The following is a description of a gene set: studied in species Homo sapiens from publication La Manno G, Gyllborg D, Codeluppi S, Nishimura K, Salto C, Zeisel A, Borm LE, Stott SRW, Toledo EM, Villaescusa JC, Lönnerberg P, Ryge J, Barker RA, Arenas E, Linnarsson S (PMID 27716510) Human Gene Set: MANNO_MIDBRAIN_NEUROTYPES_HPROGFPM Cell types are named using anatomical and functional mnemonics prefixed by 'm' or'h' to indicate mouse and human respectively: OMTN, oculomotor and trochlear nucleus; Sert, serotonergic; NbM, medial neuroblast; NbDA, neuroblast dopaminergic; DA0-2, dopaminergic neurons; RN, red nucleus; Gaba1-2, GABAergic neurons; mNbL1-2, lateral neuroblasts; NbML1-5, mediolateral neuroblasts; NProg, neuronal progenitor; Prog, progenitor medial floorplate (FPM), lateral floorplate (FPL), midline (M), basal plate (BP); Rgl1-3, radial glia-like cells; Mgl, microglia; Endo, endothelial cells; Peric, pericytes; Epend, ependymal; OPC, oligodendrocyte precursor cells., and this is the list of marker genes: SDC2 (NCBI Gene Id 6383), HMGN2, SVIP, CHEK1, LMNB1, SYT4, PIMREG, HELLS, SCARNA22, RPL18, FREM1, LTBP1, RFX4, VWCE, CIP2A, MAGOHB, ALDH6A1, H3C2, CSRP2, MLLT3, FOXA2, HES1, LRATD2, ACTL6A, PLEKHA5, TYMS, ASPM, UCP2, LGR5, NPM1, RPA3, GPRC5C, PLIN3, TCF12, N4BP3, PGGHG, H2BC11, IMMP1L, PIF1, ANP32E, HJURP, PLIN2, CHST9, ARHGAP11A, PROM1, SLC6A8, TMPO, SNRPF, ZFP36L1, RPL23A, KNL1, SPAG5, IGDCC4, PTTG1, NXPH2, OTX2-AS1, HMGA1, SIVA1, CKAP2L, CCDC34, GASK1B, CDC25C, EFS, WNT1, AK4, ANLN, SPDL1, TENM4, CNPY1, MAP3K20, VIM, YAP1, CKS1B, DSG2 (NCBI Gene Id 1829), RNF175, HNRNPA1P1, FLRT2, PKIB, TOP2A, INPPL1, MAT2B, HMGB2, KLHDC8B (kelch domain containing 8B), TP53TG1, NAP1L1, H4C6, EN2, CAP2, ATAD2, CLSPN, MMP2, CHAF1A, RPL26, MBNL2, PRTG, SGO2 (NCBI Gene Id 151246), HMGN5, TWIST1, CHRDL1, KIF2A, JAM2, REST, GTSE1, RPL36A-HNRNPH2, DCC, COL2A1, KIF14, BRCA2, BMP7, DBF4, KIF11, SFRP2, PHGDH, DEK, TMSB15A, CDC25B, C6orf118, STON1, IGFBP2, EEF1D, MT1X, CDKN3, CDC25A, UBE2S, RBMX, KIF2C, DANCR, CCN1, KIF18A, KIF23 (NCBI Gene Id 981), H4C11, LMX1A, GSTP1, MDK, HMGB1, TTK, CKS2, DIPK2A, EPHB2, TMEM132C, UHRF1, PTPRO, DHFR, C21orf58, ENSG00000255647, GINS1, MRPL22, TROAP, RNASEH2A, FOXA1, TDP1, ITGB3BP, MIS18BP1, CNTN6, SYNE2, FAM72A, MBD4, WNT5A, SOX2, PIH1D1, GALNT7, LMX1B, H2AZ1, ARL4A, NR2F6, CCDC8, DDC, FREM2, RRM2, GMNN, LIX1, TPBG, PAICS, CTNNAL1, MRPS15, DEPDC1, HSH2D, HMMR, GNG5, MIR99AHG, C19orf48P, FBLN1 (fibulin 1), ECT2 (NCBI Gene Id 55710), CPSF3, CEP152, ZMAT4, KRT19, CENPE, RBM24, PBK, OTX2, SNORD22, CDCA5, NCAPD2, LRP2, KCNQ2, PRC1, CCND1, DMRTA2, CCNB1, PLK1, RCN1, WEE1, H2AC25, MKI67, NCAPH, UBE2T, CCNB2, SPC25, SDC1, TMEM123, PMAIP1, KIF22, EPHB4, CKAP2, NCAPG, ADAMTS6, TMPO-AS1, SHROOM3, SOX21, STMN1, H4C12, HK2, SLF1, TFF3, MID1, GULP1, KPNA2, ARX (aristaless related homeobox), SRF, RAD51AP1 (RAD51 associated protein 1), ESCO2, NCAPG2, GPX8, PTX3, AURKB, SKA3, GINS2, KIF4A, CRNKL1, DSN1, RFC4, RPL13AP5, CENPW, RPS14, SALL4, CDK1, CDCA8, IGF2BP1 (NCBI Gene Id 201194), CHN2, MARCO, SMC4, UBE2C, CEBPA, FNDC1 (fibronectin type III domain containing 1), CSTF3-DT, HMGB3, PRDX2, SFXN2, H3C3, SEPTIN1, RPS19, ARHGEF26, NES, DIS3L2, NUF2, CENPQ, KIF2B, NUSAP1, HILPDA, CENPN, RCOR2, FANCB, GBX2, POU3F1, MCM2, SALL1, CTNNBL1, FAM83D, TRIM59, TOX3, CEMIP2, RPS3, ZWINT, AJUBA, TXLNB, PDPN, PDGFC, MND1, BIRC5, LOXL2, TACC3, HADH, NEK2, MEST, EXOSC8, LDHA, HUNK, MSI1, AURKA, HMGA2, TPX2, ANTXR1, DEPDC1B, DSC2, NPY, CDCA3, CRB2, BUB1, PIEZO2, IGDCC3, SLC4A1, BUB1B, IRS1, AP5M1, VRK1, BMP4, C22orf15, TBL1X, CNN2 (NCBI Gene Id 1265), RMST, KIF15, ERF, CCNA2, PTGR1, MAGT1, SGO1, FOXM1, ADAMTS5, RACGAP1, CENPK, SMC2, DLGAP5, KNSTRN, BRCA1, KDM4A-AS1, CENPU, CENPF, PARPBP, H4C9, MAD2L1, RTKN2, RAN (RAN, member RAS oncogene family), H2BC9, LGI1, SNRPC, CRYZ, GTF2H2, GAS2, MELK, PRR11, H3C7, TEAD2, FANCI